Given this list of marker genes Il6ra, Wt1, Itgb3, Bmp4, C3ar1, Bmp7, Pdgfd, Pdgfa, Ifng, Pdgfrb, Serpinb7, Pdgfb, Cflar, Egr1, here is a description of the gene set: Mouse Gene Set: GOBP_GLOMERULAR_MESANGIAL_CELL_PROLIFERATION species: Mus musculus The multiplication or reproduction of glomerular mesangial cells, resulting in the expansion of the population.